The following is a description of a gene set: The series of molecular signals initiated by binding of the cysteine knot protein Norrin to a Frizzled 4 (Fzd4) family receptor on the surface of the target cell and ending with a change in cell state. Mouse Gene Set: GOBP_NORRIN_SIGNALING_PATHWAY species: Mus musculus, and this is the list of marker genes: Ndp, Lrp5 (NCBI Gene Id 16973), Tspan12, Fzd4, Lrp6